The following is a description of a gene set: from publication Chen Y, Wang X (PMID 31504780) species: Homo sapiens Genes predicted to be targets of miRBase v22 microRNA hsa-miR-4315 in miRDB v6.0 with MirTarget v4 prediction scores > 80 (high confidence targets). Human Gene Set: MIR4315, and this is the list of marker genes: VCP, TSEN2, CAVIN2, SGO1, PDCD10, ZMYM3